Given this list of marker genes OSM, MED1, TYROBP, POLR3B, WASHC4, NFKBIL1, KCNK13, KCNK6, C2CD4B, ZDHHC3, PELI1, PPP6C, TNIP3, KLK7, KLK3, MIR144, MARK4, NLRC5, HYAL2, LY96, RBM47, LGALS9, TNIP1, PLA2G7, LRRC19, MAPK3, CLEC6A, ELP6, MIR19A, RNF31, CAMK2N1 (calcium/calmodulin dependent protein kinase II inhibitor 1), RAB11FIP2 (RAB11 family interacting protein 2), FCN1, MIR210, MIR520E, SLC19A1, ZDHHC5, TIRAP, GPATCH3, HLA-G, AARS2, RNF39, UFD1, IL2, STAT5A, MIR20A, RSAD2, GPS2, REG3G, SIRT2, OASL, TLR2, PTGER3, CHUK, MIR708, COLEC10, ZCCHC3, ZBP1, ARG1, CD300A, LILRA4, MEF2C, CRTAM, RIGI, UBQLN1, MIR146A, ZP3 (NCBI Gene Id 7785), MATR3, GRAMD4, HPX, SRC, CD160, GPR4, OTUD4, LRRC14, P2RX7, SCARA3, SCIMP, MNDA, TLR8, IL17RA, FCN2, NR1D1, NOD1, TRIM62, ZDHHC9, TICAM2, EPG5, LAG3, IDO1, XRCC6, COLEC12, USP29, INAVA, IL17RB, HCFC2, DDX41, DHX9, DDX60, IL17A, RNF34, CLOCK, OSMR, GBP2, POLR3C, CD14, STING1, ACOD1, SIN3A, BIRC3, RNF170, WNT5A (NCBI Gene Id 7474), IRAK4 (NCBI Gene Id 95458), APP, IL12B (NCBI Gene Id 7907), IKBKB, AGT, MYD88, NLRX1, HMGB1, RNF144A, POLR3F, C1QBP, PTGS2, MIR128-1, TNFRSF11A, BTK, PLCG2, ZNRF4, PQBP1, DDX3X, IL23A, PPT1, NINJ1, AP3B1, UNC93B1, MIR181B1, TRIM11, TRIM5, NPLOC4, CD226, ANKRD17, CCL24, IL12A, S100A12 (NCBI Gene Id 6283), ERBIN, AKT1, RBM14, CLNK, IFI35, HTR2A, TRIM25, KIR2DL4, GRN, WDFY1, GDI1, LAMP1, IL17F, PYDC5, SNCA, KCNJ8, LRSAM1, ARRB2, ADORA2B, DDT, RTN4, IL16, PARP9, GBP5, HDAC6, LTA, OPTN (optineurin), SLC46A2, CCN4, VAV1, TRIL, POMC (proopiomelanocortin), PIK3AP1, CADM1 (NCBI Gene Id 337934), MIR22, NLRP10, ESR1, TLR10, PRKDC, IFNG, CREBBP (NCBI Gene Id 1387), IFIH1, MAPK13, CD28 (CD28 molecule), TREX1, CLPB (ClpB family mitochondrial disaggregase), LAMP2, TNFAIP3, STAT5B, NKG7, PUM1, FFAR2, ETS1, DAB2IP, CTSC, TGFB1, CD47, FBXL2, IL18, CYLD, HAVCR2, LYN, CASP5, PTGER4, IL33, TASL (TLR adaptor interacting with endolysosomal SLC15A4), COLEC11, LGR4, KLRC3, SPSB3, NLRP1, S100A9, FLOT1, KLK5, DEFB114, CCL3, IL1RL1, IL1B, PYHIN1, ZDHHC12, IRF1, TLR3, FFAR3, MAPKAPK2, LGALS1, TLR1, MIR200B, GBP3, NLRP6, CACTIN, MIR206, BIRC2, GBP1, FOSL1, CD36, IKBKE, FCRL3, KLRC4, TIFAB (NCBI Gene Id 497189), OAS1, RNF185, SYK, TRAF3IP3, TNF, HMGB2, IRGM (immunity related GTPase M), TRPV4, SLAMF6, MGST2 (NCBI Gene Id 4258), ZNFX1, EMILIN2, TRIM32, USP50, MIR200C, STAP1, MBL2, ZNRF1, FLOT2, MIR149, ABHD8, NFKBIA (NCBI Gene Id 4792), PAK1, TNFSF11, NOD2, CARD8, EIF2AK2, MAVS, ZDHHC4, LSM14A, PDCD4, CX3CL1, NAIP, ITCH, TAX1BP1, CASP4, TAFA3, NUPR1, TIFA, LACC1, PYCARD, FEM1A, TLR7, HSPA8, IRF5, TRIM41 (NCBI Gene Id 90933), SUCNR1, IRAK1, CASP1, EREG, KLRD1, PAK2, TRIM31, GKN2, TNFRSF1A, UCN, NLRP3, CSNK1A1, UBE2K, PIK3CG, CAV1, MMRN2, POLR3D, TLR6, PJA2 (praja ring finger ubiquitin ligase 2), PSPC1, ATAT1, APPL2, MFHAS1, KLRC2, HSP90AA1, TARBP2, KLRK1, CEBPA, PHB1, RELA, TRIM15, PPP2CA, TLR4, PLSCR1, CCDC134, IFI16, PARP1, USP27X, PGC, USP17L2, CYBA, MAPKAPK3, C2CD4A, PVR, CD81, TSPAN6, LDLR, EP300, RNF115, LYPLAL1 (NCBI Gene Id 127018), LILRA5, SFPQ, TRIM56, TTBK1, RIPK1, VAMP7, CPT1A, PTPN22, S100A8, RAET1E, BANF1, SNX4, AKIRIN2, MIR21, CPTP, PDE2A, STMP1, FADD, KARS1, TAB1, EMILIN1, PIK3R1, DHX58, MAP2K6, SQSTM1, ALPK1, SLC15A2, RPS6KA3, GPRC5B, NLRC4, NEK7, ADAM8, TRADD, RAB7B, LBP, XIAP, RIOK3, RNF135, TRIM3, TICAM1, POLR3G, KLRC4-KLRK1, NFKBIZ, CASP12, KIR2DS2, PTPRS, SEC14L1, OGT, ZDHHC18, TMEM126A, NCR3, HEXIM1, APPL1, HLA-E, MIR142, S100A14 (NCBI Gene Id 57402), TKFC, SH2D1B, TOMM70, CD300LF, PLA2G5, NAGK, MIR17, PDPK1, CASP3, BPIFB1, TRAF6, NPAS2, IRF4, SERPINE1, IL21, LPL, OAS3 (2'-5'-oligoadenylate synthetase 3), SLC15A3, HSPA1B (heat shock protein family A (Hsp70) member 1B), MIR4691, SETD4, SIGLEC16, KAT5, FCGR1A, LETMD1, PLA2G2A, NEAT1, GRPR, RNF125, PUM2, IRF7, TLR9, IL18RAP, LRRK2, PARK7, MIR520B (microRNA 520b), TXK, NR1H4, HCK, CREB3L3, GSDMD, TLR5, LRCH4, PCBP2 (NCBI Gene Id 5094), FCN3, LTF, YWHAE, VAMP8, CARD9, SMPDL3B, NMI, GRP, AP1G1, NONO, TYRO3, SLC15A4 (solute carrier family 15 member 4), MIR92A1 (microRNA 92a-1), TNIP2, NAPEPLD, SPI1, AURKB, PHB2, IRAK3, MEFV (NCBI Gene Id 4210), TSLP, SH2D1A, NLRP12, KLRC1, HSPA1A, FCER1G, PYDC2, FPR2, BCL10, SARM1, IL6, MDK, HLA-F, TREML4, GPR108, CEBPB, MMP8, NOP53 (NOP53 ribosome biogenesis factor), AGTR1, CRH, FYN, CCR7, TRIM65 (NCBI Gene Id 201292), TNFSF4, TBK1, PYDC1, IL6ST, PENK, NAGLU, MMP12, ABHD17A, C3, F2RL1, CCL5, ZC3HAV1, IFNB1, PRKD1, CLEC4E, RIPK2, NECTIN2, RPS19, NLRP2B, SMPDL3A, TRAF3, RAET1G, MARCHF5, BRCC3, CASP6, LGALS2, LATS2, MIR140, LILRA2, PAK3, ABCC1 (ATP binding cassette subfamily C member 1 (ABCC1 blood group)), HSPD1, USP15, TRIM6, PLA2G3, GPSM3, RASGRP1, XRCC5, NLRC3, AIM2, NR1H3, FABP4, CD274, ZDHHC1, CCL1, TREM2, CTSS, CLEC7A, MAPK8, NPY5R, IRAK2, CCR2, DHX33, RFTN1, HSP90B1, LATS1, CD1D (CD1d molecule), IRF3, PRKCE, TAC1, BECN1, CGAS, IFNK, OTULIN, GFI1, ECSIT, IL15, TNFSF18, MAP3K8, MIR126, IPO5, MAP3K7, RASGRP4, here is a description of the gene set: Human Gene Set: GOBP_POSITIVE_REGULATION_OF_DEFENSE_RESPONSE species: Homo sapiens Any process that activates or increases the frequency, rate or extent of a defense response.